The following is a description of a gene set: Hormone ligand-binding receptors studied in species Mus musculus Mouse Gene Set: REACTOME_HORMONE_LIGAND_BINDING_RECEPTORS, and this is the list of marker genes: Tshr, Gnrhr, Gnrh1, Fshb, Lhb, Lhcgr (NCBI Gene Id 16868), Cga, Tshb, Fshr, Gphb5, Gpha2